Given this list of marker genes WDR11, TACR3, SPRY4, FLRT3, PROKR2, SOX10, FGFR1, IL17RD, PROK2 (NCBI Gene Id 60675), SEMA3A, DUSP6, HESX1, FEZF1, ANOS1, CHD7, CCDC141, NDNF, DCC, FGF17, FGF8, HS6ST1, here is a description of the gene set: Human Gene Set: HP_ABNORMAL_GONADOTROPIN_RELEASING_HORMONE_CONCENTRATION A deviation from the normal circulating concentration of the normal gonadotropin-releasing hormone (GnRH). Intermittent GnRH secretion from the hypothalamus acts upon its receptor in the anterior pituitary to regulate the production and release of the gonadotropins, follicle-stimulating hormone (FSH) and luteinizing hormone (LH). Abnormal gonadotropin-releasing hormone concentration studied in species Homo sapiens